Given this list of marker genes LYZL6, CHMP2B, SPTBN1, MICALL1, PACSIN1 (protein kinase C and casein kinase substrate in neurons 1), MYH10, COL6A1, TPST2, SERINC5, ARV1, IZUMO1R, NHERF1, TMEM63B (NCBI Gene Id 55362), ARL8B, VPS4B, RAB3A, DNM2, PLSCR3, P2RX7, SNX33, CRISP1 (cysteine rich secretory protein 1), C16orf92, FOLR1, AKT1, GSN, PLSCR4, ROPN1B, SPACA6, FNBP1L, CAV3, STX2, ILK, A4GALT, HDAC3, ABCD1, CHMP1B, XKR9, PTPRC, SNX18, WHAMM, PTEN, FLOT1, SPACA3, STX4, BIN3, MTSS1, PLEC, PLSCR2, MYRF, CAV1, TIE1, CR1, SPATA46, TMEFF2, FA2H, TRIM72, CRB1, TLCD2, PLSCR1, SYTL4, ANO9, SERINC2, MTSS2, IZUMO1, SERINC3, EMP2, PALS1, BAIAP2L1, ABCD2, NDRG1, LARGE1, SPACA5B, CSRP3, CHMP4A, LLCFC1, MIR138-1, MYMK, DCST2, AR, ANO3, WASL, NOX1 (NCBI Gene Id 27035), FOLR3, CHMP2A, ANO5, VDAC2, ADAM2, SNX9, TMEM95, ATP2A2, ANK3, XKR6, CLPTM1L, EHD2, GLIPR1L1, PACSIN3, FOLR2, ATG9A, CLN3, S100A10, COL5A1, ANO6, SOD1, BIN1, TMEM41B, SERP1, CHMP1A (NCBI Gene Id 5642), LYZL4, WDR54, ANO4, ATG9B, CLU, CASP7, SERPINA5, NOX5, CHMP4C, IQGAP1, EPB41L3, SPTA1, XKR8, BAIAP2 (BAR/IMD domain containing adaptor protein 2), PLSCR5, DEGS1, NSF, SYPL2, BIN2, TLCD1, SPACA5, DMKN, CHMP6, BAIAP2L2, ANK2, EQTN, CHMP5, MYH9, CHMP4BP1, ANO7, MIR26A1, FASLG, GRXCR1, MYOF, FREY1, ANXA2, CAV2, VMP1, ASAP1, SPPL2C, SLC4A1, TRPC5, TGFB2, XKR4, AHNAK, ABCA7, XRCC4, MYMX, ATP8B1, SYT7, CAVIN2, CHMP7, DCST1, CHMP4B, SH3GLB1, MAFB, CHMP3, VPS4A, SMPD1, CD9, XKR7, CXCR4, SYT11, PRX, OSBPL2, SPAM1, SH3TC2, AKT2 (AKT serine/threonine kinase 2), PACSIN2, COLEC12, UGCG, SPESP1, ATP10A, here is a description of the gene set: A process that is carried out at the cellular level which results in the assembly, arrangement of constituent parts, or disassembly of the plasma membrane. species: Homo sapiens Human Gene Set: GOBP_PLASMA_MEMBRANE_ORGANIZATION